The following is a description of a gene set: The Josephin domain is present in four human DUBs: Ataxin-3 (ATXN3), ATXN3L, Josephin-1 (JOSD1) and JOSD2. All have been shown to possess DUB activity (Tzveltkov & Breuer 2007, Weeks et al. 2011). Josephin domain DUBs may specialize in distinguishing between polyubiquitin chains of different lengths (Eletr & Wilkinson 2014). Reactome Pathway: Josephin domain DUBs species: Homo sapiens part of: Deubiquitination, and this is the list of marker genes: RAD23B, PRKN, UBB, UBA52, UBC, RAD23A, RPS27A, ATXN3L, JOSD2, VCP, ATXN3, JOSD1